The following is a description of a gene set: Binding to a DNA D-loop. A D-loop is a three-stranded DNA structure formed by the invasion of a single DNA strand that base pairs with one strand of duplex DNA, while the rest of the double-stranded DNA does not unwind. studied in species Homo sapiens Human Gene Set: GOMF_D_LOOP_DNA_BINDING, and this is the list of marker genes: BLM, POT1, RECQL4, WRN, RAD51AP1